Given this list of marker genes SGK1, TNFRSF12A, SRSF5, EWSR1, EFNA1, H4C2, H2AC8, CCNK, TXNRD1, FUBP3, BACE2, LIMA1, H1-0, SH3BP5, NFKBIA, IL6, KYNU, MYC, ELF3, IER3, HNRNPH1, FHL2, MCL1, TRAF4, SDCBP, NFE2L2, CCND1, TOP2A, CD83, MAP2K3, ANPEP, SYNCRIP, COL7A1 (NCBI Gene Id 1294), here is a description of the gene set: Human Gene Set: DORN_ADENOVIRUS_INFECTION_12HR_DN The infection of human cells by adenoviruses leads to a gradual reduction in the activity of host cell functions while viral gene expression progresses in a regulated way. We used the DNA microarray technique to determine the transcriptional activity profiles of cellular genes upon infection with adenovirus type 12 (Ad12). The microarray data were validated by quantitative real-time PCR for genes which showed significant alterations after Ad12 infection. At 12 h postinfection, there is a striking up-regulation between 10- and 30-fold in the expression of the G1P2, IFIT1, and IFIT2 cellular immune response genes compared to mock-infected cells. At later stages of infection, when the majority of regulated cellular genes has been turned down, a limited number of cellular genes exhibit increased activities by factors of 3 or less. These genes belong to the signal transduction or transcriptional regulator classes or are active in protein degradation, like ANPEP, an aminopeptidase. The SCD and CYP2S1 genes function in lipid metabolism. The eucaryotic translation initiation factor 4 is up-regulated, and one of the major histocompatibility complex genes is diminished in activity. For two of the genes, one up-regulated (CTSF gene) and one down-regulated (CYR61 gene), alterations in gene activity were confirmed at the protein level by Western blotting experiments. Increased genetic activity of cellular genes late in adenovirus infection has not been reported previously and demonstrates that Ad12 has a sustained control of host cell gene expression well into the late phase of infection. Genes down-regulated in HeLa cells (cervical carcinoma) 12 h after infection with adenovirus Ad12. from publication Dorn A, Zhao H, Granberg F, Hösel M, Webb D, Svensson C, Pettersson U, Doerfler W (PMID 15681441) species: Homo sapiens